Given this list of marker genes DNAJC30, GPR143 (G protein-coupled receptor 143), TMEM270, CLIP2, GTF2IRD1, STX1A, RFC2, BAZ1B, VPS37D, TBL2, NCF1, GTF2IRD2, METTL27, EIF4H, FKBP6, GTF2I, LIMK1, ELN, BUD23, here is a description of the gene set: species: Homo sapiens Human Gene Set: HP_NYSTAGMUS_INDUCED_HEAD_NODDING Nystagmus-induced head nodding Head movements associated with nystagmus, that may represent an attempt to compensate for the involuntary eye movements and to improve vision.